The following is a description of a gene set: Radioulnar synostosis species: Homo sapiens Human Gene Set: HP_RADIOULNAR_SYNOSTOSIS An abnormal osseous union (fusion) between the radius and the ulna., and this is the list of marker genes: DNAJC30, SF3B4, PTPN11, ESCO2, SMC3, FKBP6, LRP4, SALL4, NCF1, SOS2, MAF, FGFR3, B3GAT3, CPLX1, BRD4, NRAS, RAD21, TBX22, ELN, STX1A, TWIST1, RAF1, BICRA, CLIP2, BUD23, RRAS2, SETBP1, TBL2, EIF4H, GTF2IRD2, POR, DONSON, APC, COLEC10, HDAC8, LETM1, TBX5, LZTR1, FGFRL1, CBL, CHST3, RIT1, METTL27, NIPBL, RASA2, FGFR2, RRAS, CSGALNACT1, MLXIPL (MLX interacting protein like), BCOR, XYLT1, KAT6B, TAF6, GTF2I, SMAD6, COLEC11, CANT1, KRAS, DHODH, PIEZO2, RFC2, SOS1, MRAS, CTBP1, CHSY1, B3GALT6, BAZ1B, NSD2, TMEM270, LIMK1, SMC1A, SPRED2, MECOM, VPS37D, MASP1, B4GALT7, RPL26, GTF2IRD1, HOXA11